The following is a description of a gene set: species: Mus musculus Any process that activates or increases the frequency, rate or extent of protein localization to cell cortex. Mouse Gene Set: GOBP_POSITIVE_REGULATION_OF_PROTEIN_LOCALIZATION_TO_CELL_CORTEX, and this is the list of marker genes: Epb41l2, Ppp1r9b (protein phosphatase 1, regulatory subunit 9B), Numa1, Epb41, Gpsm2, Gnai1